The following is a description of a gene set: Mouse Gene Set: MIR_223_3P from publication Chen Y, Wang X (PMID 31504780) Genes predicted to be targets of miRBase v22 microRNA mmu_miR_223_3p in miRDB v6.0 with MirTarget v4 prediction scores > 80 (high confidence targets). species: Mus musculus, and this is the list of marker genes: Cbx5, Smurf2, Acp3, Rcn2, Mcc, Nipal3, Hlf, Gpr155, Tent5a, Prdm1, Myh10, Armcx1, Jmy, Usp40, Ptprh, Adgrb3 (adhesion G protein-coupled receptor B3), Phlpp1, Lelp1, Tshz3, Serpinb1b, Crim1, Kpna3 (NCBI Gene Id 16648), Nhlh2, Gtpbp8, Rab8b, Ndnf, Letm1, Anks1b, Acvr2a, Mybl1, Wwtr1, Rubcnl, Zcchc14, Hmgcs1, Sytl3, Papola, Ptbp2, Inpp4a, Srek1, Mcmbp, Relch, Card14 (caspase recruitment domain family, member 14), Ube2a, Crmp1, Lmo2, Dusp10, Zxdc, Brinp1, Ulk2, Klhl14, Cd2ap, Mbnl1, Siah1a, Cxcl10, Cldn11, S1pr1, Synj2, Hsp90b1, Tmem229a, Cers6, Septin6, Cldn18, Brwd1, Pole4, Fbxo8, Sp3, Acsl3, Septin8, Mecp2, Eva1a, Nfib, Mmp16, Gpr22, Mpz, Tent5d, Igf1r, Garre1, Fam89a, Nfia, Kctd4, Rasa1, Cbfb, F3, Gk, Dennd5b, Tgfbr3, Cdk17, Slc4a4, Stim2, Eaf1, Pi4k2a, Phip, Slc39a1, Ddit4, Nfat5, Fbxw7, Rhob, Bin3, Phf20l1 (PHD finger protein 20-like 1), Fam199x, Zfp113, Mbip, Osgepl1, 2310057M21Rik, Dusp2, Xcr1, Atp7a, Rras2, Cox11, Ankrd17, Plekhh1